The following is a description of a gene set: Human Gene Set: REACTOME_CARGO_TRAFFICKING_TO_THE_PERICILIARY_MEMBRANE Cargo trafficking to the periciliary membrane species: Homo sapiens, and this is the list of marker genes: CCT3, INPP5E, EXOC5, EXOC1, EXOC6, BBS1, MKKS, NPHP3, CCT8, CCT2 (NCBI Gene Id 10576), UNC119B, PKD2, BBS4, TTC8, CNGA2, SSTR3, ASAP1, BBIP1, BBS7, TCP1, BBS5 (Bardet-Biedl syndrome 5), RHO, EXOC8, SMO, EXOC2, GBF1, BBS12, PDE6D, ARF4, RAB11A, BBS9, EXOC3, CNGB1, PKD1, BBS2, CYS1, LZTFL1, ARL3, RAB8A, EXOC4, RAB11FIP3, CNGA4, ARL13B, CCT4, ARL6, BBS10, RAB3IP, EXOC7, MCHR1, CCT5, RP2